Given this list of marker genes Foxc1, Tacstd2, Mir34a, Sox6, Tgfb2, Gsk3b, Fgf2, Ptn, Rbm24, Crxos, Sox5, Tcf15 (transcription factor 15), Mtch2, Pwp1, Tbx5, Sirt6, Men1, Dhx36, Vsir, Sp7, Sox9, Nr5a2, Sox17, Nkx2-5, Nudt21, Hoxb4, Mir100, Ltbp3, Nr6a1, Mir137, here is a description of the gene set: studied in species Mus musculus Mouse Gene Set: GOBP_POSITIVE_REGULATION_OF_STEM_CELL_DIFFERENTIATION Any process that activates or increases the frequency, rate or extent of stem cell differentiation.